Given this list of marker genes E130308A19Rik, Slc10a1, Retnlb, Igsf10, Grb2, Esrrg, Ppme1 (NCBI Gene Id 72590), Plp1, P4ha2, Tardbp, Rfx6, Zfand3, Hic2, Dusp22, Cd200r3, Brd1, Mdga2, Apbb2, Zfp148, Lpgat1, Col11a1, Adra1a, Ar, Npas3, Tnrc6b, Septin2, Gria3, Cxxc4, Rasgrp1, Carm1, Cox19, Gpr63, Hacd4, Ttc17, Ccnyl1, Net1, Tmem30a, Dab1, Hivep2, Gm14296, Terb2, Gm4724, Mrm1, Eif5b, Rab27b, Cd164, Pbx3, Brcc3, Trim9, Fgf18, Cdv3, Faf1, Oxr1, Nr2c1, Wdr76, Syt9, Tmem201, Foxp2, Actmap, Mex3a (NCBI Gene Id 72640), Usp49, Axin2, Ccng1, Zmym5, Slc24a2, Trip11, Nr0b1, 2210418O10Rik, Zfp953, Slx1b, Rpp30, Gm14308, Marchf10, Cd69, Csnk1g1, Zfhx3, Cenpp (centromere protein P), Micos10, Mif4gd, Rnf207, Cpped1, Rbms3, Mbnl1, Acsl1, Gnb1, Spred1, Phf20l1, Cd34, Zfp280d, Rps6ka2, Ykt6, Pou2f2 (NCBI Gene Id 18987), Ephb1, Alkal2, Stxbp5l, Zkscan8, Tgfbi, Gja3, Wnk1, Twf1, Plxna4, Crebl2 (NCBI Gene Id 57903), Lurap1l, Card6 (caspase recruitment domain family, member 6), Ctdnep1, Fbln5, Kcnb1, Kdm4a, Mthfd2, Runx1t1, Rbpms2, Gk2, Arvcf, Abca4, Ark2n, Tnks, Zfp607b, Itpa, Prkg1, Retreg1, Ifrd2, Kctd8 (potassium channel tetramerisation domain containing 8), Nkapd1, Nr2f6, Cacna2d3, Bmp2k, Ap1s2, Gm2026, Ralbp1, Adam23 (NCBI Gene Id 98648), Gm4847, Rem2, Synpo2l, Golph3l, Tlk1, Robo2, Gm14434, Jph1 (junctophilin 1), Rab11fip5, Fzd10, Stk3, Psmb11, Rin2, Cacnb4, Ubqlnl, Lzic, Gys1, Sgip1, Pitx2, Cntnap2, Idi2, Pde3b, Gpr88, Ubxn7, Frmd3, Insig1 (NCBI Gene Id 69039), Nfasc, Col1a2, Nedd4l, Yme1l1, Nrg3, Zfp654, Thrap3, Gramd2b, Trim8, Sema6d, Lrat, Ntf5, Sorl1, Wipf3, Cnep1r1, Trpc3, Tead1, Rab18, Prkaa2, Tab3, Alg2, Onecut2, Maml3, Mgat1, Fgf5, Nhsl3, Hcn1, Tent5c, Ranbp9, here is a description of the gene set: Mouse Gene Set: MIR_6338 from publication Chen Y, Wang X (PMID 31504780) Genes predicted to be targets of miRBase v22 microRNA mmu_miR_6338 in miRDB v6.0 with MirTarget v4 prediction scores > 80 (high confidence targets). studied in species Mus musculus